The following is a description of a gene set: Polo-like kinase mediated events Human Gene Set: REACTOME_POLO_LIKE_KINASE_MEDIATED_EVENTS studied in species Homo sapiens, and this is the list of marker genes: WEE1, CCNB2, LIN37, PKMYT1, RBBP4, CDC25C, LIN52, PLK1, EP300, LIN9 (lin-9 DREAM MuvB core complex component), CENPF, CCNB1, MYBL2, LIN54, CDC25A, FOXM1